Given this list of marker genes MPHOSPH8, STAT5B, BBOF1, FOS (Fos proto-oncogene, AP-1 transcription factor subunit), RGPD5, DYNC2H1, DIXDC1, ARHGEF40, NME5, NBR1, AASS, TPT1, ZNF395, ECHDC2, STARD13, AKAP11, DZANK1, NYNRIN, NF1, RNASE4, IFT88, TP53BP1, ZFP2, ZNF862, FRY (NCBI Gene Id 404759), CTDSP1, GFOD3P, SMARCA2 (SWI/SNF related, matrix associated, actin dependent regulator of chromatin, subfamily a, member 2), LTBP3, KIF13B, PIGV, DEAF1, SYNC, CRTC3, RUNX1, CIRBP, JHY, TBC1D17, LAMB2, SIRT3, SNX1, IFT46, CRY2, BBS1, CFAP69, CASP9, CX3CR1, MARCHF8, CYBRD1, ARHGEF12, WDR19, SLC24A1, SESN1, here is a description of the gene set: BACKGROUND: Histologic grade in breast cancer provides clinically important prognostic information. However, 30%-60% of tumors are classified as histologic grade 2. This grade is associated with an intermediate risk of recurrence and is thus not informative for clinical decision making. We examined whether histologic grade was associated with gene expression profiles of breast cancers and whether such profiles could be used to improve histologic grading. METHODS: We analyzed microarray data from 189 invasive breast carcinomas and from three published gene expression datasets from breast carcinomas. We identified differentially expressed genes in a training set of 64 estrogen receptor (ER)-positive tumor samples by comparing expression profiles between histologic grade 3 tumors and histologic grade 1 tumors and used the expression of these genes to define the gene expression grade index. Data from 597 independent tumors were used to evaluate the association between relapse-free survival and the gene expression grade index in a Kaplan-Meier analysis. All statistical tests were two-sided. RESULTS: We identified genes in our training set that were associated with histologic grade; most of these genes were involved in cell cycle regulation and proliferation. In validation datasets, the gene expression grade index was strongly associated with histologic grade 1 and 3 status; however, among histologic grade 2 tumors, the index spanned the values for histologic grade 1-3 tumors. Among patients with histologic grade 2 tumors, a high gene expression grade index was associated with a higher risk of recurrence than a low gene expression grade index (hazard ratio = 3.61, 95% confidence interval = 2.25 to 5.78; P <.001, log-rank test). CONCLUSIONS: Gene expression grade index appeared to reclassify patients with histologic grade 2 tumors into two groups with high versus low risks of recurrence. This approach may improve the accuracy of tumor grading and thus its prognostic value. Down-regulated genes whose expression correlated with histologic grade of invasive breast cancer tumors: comparison of grade 1 vs grade 3. Human Gene Set: SOTIRIOU_BREAST_CANCER_GRADE_1_VS_3_DN studied in species Homo sapiens from publication Sotiriou C, Wirapati P, Loi S, Harris A, Fox S, Smeds J, Nordgren H, Farmer P, Praz V, Haibe-Kains B, Desmedt C, Larsimont D, Cardoso F, Peterse H, Nuyten D, Buyse M, Van de Vijver MJ, Bergh J, Piccart M, Delorenzi M (PMID 16478745)